The following is a description of a gene set: from publication McBryan J, Howlin J, Kenny PA, Shioda T, Martin F (PMID 17486082) species: Mus musculus Genes down-regulated during pubertal mammary gland development between week 4 and 5. Human Gene Set: MCBRYAN_PUBERTAL_BREAST_4_5WK_DN Expression microarray analysis identified over genes regulated during puberty in the mouse mammary gland. Most prominent were genes whose expression increased in parallel with pubertal development and remained high thereafter. Members of the Wnt, transforming growth factor-beta and oestrogen-signalling pathways were significantly overrepresented. Comparison to expression data from CITED1 knockout mice identified a subset of oestrogen-responsive genes displaying altered expression in the absence of CITED1. Included in this subset are stanniocalcin2 (Stc2) and amphiregulin (Areg). Chromatin immunoprecipitation revealed that ERalpha binds to oestrogen response elements in both the Stc2 and Areg genes in the mammary gland during puberty. Additionally, CITED1 and ERalpha localize to the same epithelial cells of the pubertal mammary gland, supporting a role for interaction of these two proteins during normal development. In a human breast cancer data set, expression of Stc2, Areg and CITED1 parallel that of ERalpha. Similar to ERalpha, CITED1 expression correlates with good outcome in breast cancer, implying that potential maintenance of the ERalpha-CITED1 co-regulated signalling pathway in breast tumours can indicate good prognosis., and this is the list of marker genes: DMAC2, LAMA4, STOM, CCNK, PRKCE, FSCN1 (NCBI Gene Id 6624), PPP1R8, HLA-DQA2, CIDEA, PTGES2, CAVIN1, DNM2 (NCBI Gene Id 338330), ACVR1C, ZFP91, BLTP3A, SORBS1, DBT, EPB41L2, AKT1, KCNK2, ZBTB16, ETS1, ERAL1, LASP1, LTC4S, LIPA, MCRIP2 (NCBI Gene Id 84331), ACACA, AKT2, MLX, FABP3, RETNLB, UCP1, YKT6, TPSB2, EHD1, GM2A, QKI, CYTH1, NEAT1, PEX6, MLXIPL, JAG1, APOC2, IGFALS, CSPG4, PLIN5, UBE3A, KIF1C, UBE4A, ACADVL, GRB10, GYS1, BCHE, RAB5B, IMMT (NCBI Gene Id 10989), GID4, SFXN1, KDM5C (NCBI Gene Id 8242), P2RX5, GPD1, AATK, ZFAND5, DLAT, RPS6KA3, TSPAN17, LGALS12, SOD3, CA13, RASSF3, DDX6, TNS1, SUCLG1, PYCR1, EXTL3, CUX1, MTARC1, GPAM, PPARGC1B, YWHAG, KLHL2 (kelch like family member 2), ATPAF2, KLF15, LRP5, DMPK, NID1, SLC2A4, VEGFA, CCN1, PRKACB, RBBP4, SLC7A10, ECI1, NOTCH4, ST6GALNAC5, ALDH1L1, COQ8A, KCNK3, NIPSNAP3A, NNAT, NFIC, ZNF106, MYO1C, EPAS1, ART3, ACAD9 (acyl-CoA dehydrogenase family member 9), ANXA8L1, FMC1, CHRDL1, PDK4, PCMTD1, EIF4G1, CDH5, GOLPH3, SEH1L, PDK1, SCD, TIE1, SLC25A10, FABP4, ATP6V0A1, ACAA2, APLP2, PTPN14, FABP5, SLC16A2, BLCAP, PPP1R3C (protein phosphatase 1 regulatory subunit 3C), SOD2, FHL1, TMEM45B, PDCD6IP, H3C15, KCNB1, TBL1XR1, PPA1, BMP1, NID2, WEE1, SLC25A35, BPNT1, PFKFB3, CARHSP1, TMEM109, STEAP3, EDNRA, HCCS, IGFBP4, SH2B2, REEP6 (NCBI Gene Id 92840), NRK, NORAD, GALNT2, CSNK2A1, MTCH2, ACLY, ADISSP, PER3, EHHADH, GK, PRXL2B, TFRC, TPP2, MPZ, PAQR4, AHCYL1 (adenosylhomocysteinase like 1), CPT1B, LETMD1, OGT, MBTPS1, CISD1, ATP5F1D, HSPG2, ACSL1, COQ5, HIPK2, SH2B3, ACAT1, MALAT1, ECH1, RNASE3, ADRB3, TRAC, BCAT2, ETFDH, ACSF2, COX7A1, RCC1L, NDN, EHD2, ACO2, WFDC21P, MAPK8IP1, CD8A, IDH3B, NR1D1 (nuclear receptor subfamily 1 group D member 1), COX8BP, PPP6R3, PRELP, TMEM14C, CP, LPL